The following is a description of a gene set: Mouse Gene Set: WP_EUKARYOTIC_TRANSCRIPTION_INITIATION Eukaryotic transcription initiation species: Mus musculus, and this is the list of marker genes: Polr2g, Gtf2e1, Polr2i, Polr2b, Polr3e, Polr2j, Taf6, Ilk, Taf12, Ercc2, Gtf2h3, Polr2c, Polr2h, Polr1b, Polr3d, Gtf2h4, Ccnh, Taf13, Ercc3, Gtf2b, Cdk7, Polr2a, Gtf2h1, Taf7, Mnat1, Tbp, Taf9, Ak6, Polr3h, Polr1d, Polr3k, Gtf2h2, Gtf2a2, Polr2e, Polr1a, Taf5, Polr1c, Gtf2e2, Polr3b, Polr2k (polymerase (RNA) II (DNA directed) polypeptide K), Gtf2f2